Given this list of marker genes PRDX6, MYOM2 (NCBI Gene Id 9172), ENO3, KCNA7, ENSG00000228566, PTGFR, FGF6, PPP1R3A, TCEAL7, FBP2, MYBPC2, C1orf167, UTP11, CACNG1, SLC49A3, AK1, MYOT, LANCL1-AS1, FBXL22, TAS1R1, KLHL31 (NCBI Gene Id 401265), MYLK2, MYL1, MGC27382, LINC00570, SHOX, STAC3, METTL21C, GPX7, LINC03111, LINC02308, TMEM38B, SPEG, PRSS53, LINC01497, LINC01266, SNORD114-29, PDLIM3, FXR1 (NCBI Gene Id 8087), FHL3, TMEM38A, ARHGAP36, MYBPH, RNF217-AS1, ENSG00000259636, CAPN3, TRIM54, LRTM1, TPM2, KLHL41, DHRS7C, NEB, KLHL30, JPH1, TRDN, SGCB, LINC00629, ASB5, FGFRL1, DDN, IL17B, MYF6, BTF3, FAM47E-STBD1, MYH2, LINC00856, OBSCN, FHL1, ACTN3, CKM, BLCAP (NCBI Gene Id 10904), ACTA1, SNORD114-31, TNNC2, PACSIN3, CACNB1, CHRNG, LMCD1 (NCBI Gene Id 29995), MYL10, SNORD114-15, LINC00499, TEAD4, OTUD1, MYL6B, ASTILCS, VWA5A, DDIT4L, CMYA5, TTN-AS1, MYH3, USP6, AMPD1, CA3-AS1, TAL2, ASB18, MAP4K1-AS1 (MAP4K1 antisense RNA 1), BEST3, RYR1, RPS20, LINC01854, SNORD114-26, KLHL21, KIAA1671-AS1, CA3, TMEM52, CAND2, PYGM, PRKACA, HSPB2, CASQ1, PIEZO1P2, GJD4, MRLN, IP6K3, C4orf54, MYOZ1, MYL11, DNAH8, APOBEC2, MAP3K7CL, NES, ATP2A1, FZD9 (NCBI Gene Id 8326), TRIM72, KLHL40, AGL, PPDPFL, ACTN2, CALML6, MIR133A1HG, DGCR6, PPP1R27, FAM180B, DUSP13B, LINC01479 (NCBI Gene Id 101927922), C1orf105, MYPN, PDE4DIPP1, LINC01209, MYL5, ITGB6, DMPK, BIN1, SGCG, LINC01886, ZNF106, FAM230G, TRIM7, MYOM3, SRL, XIRP2, TNNT3, CFL2, DES, ATP1B4, TMEM182, LINCMD1, RPL7P3, MYBPC1, PRR32, TXLNB, KCNE5, MYL6B-AS1, MYH8, MYH1, CAVIN4, PRKAG3 (protein kinase AMP-activated non-catalytic subunit gamma 3), CACNA1S, SNHG16, MIR1-1HG, SRPK3, TNNI2, EIF4E2 (NCBI Gene Id 9470), SMTNL1, MAP6D1, ZNF556, ECPAS (Ecm29 proteasome adaptor and scaffold), SCN4A, RTN2, CRABP2 (NCBI Gene Id 1382), MEG9, SYNC, RPS3AP20, SLN, SNORD114-30, MSRB3-AS1, TBX15, SYPL2, ASB12, CAV3 (NCBI Gene Id 859), TTN, PADI2, STPG2-AS1, here is a description of the gene set: Human Gene Set: DESCARTES_MAIN_FETAL_SKELETAL_MUSCLE_CELLS Marker genes curated from the annotated cluster as represented in the Descartes Human Gene Expression During Development database. studied in species Homo sapiens The gene expression program underlying the specification of human cell types is of fundamental interest. The study authors generated human cell atlases of gene expression and chromatin accessibility in fetal tissues. For gene expression, the study authors applied three-level combinatorial indexing to >110 samples representing 15 organs, ultimately profiling ~4 million single cells. The study authors leveraged the literature and other atlases to identify and annotate hundreds of cell types and subtypes, both within and across tissues. Our analyses focused on organ-specific specializations of broadly distributed cell types (such as blood, endothelial, and epithelial), sites of fetal erythropoiesis (which notably included the adrenal gland), and integration with mouse developmental atlases (such as conserved specification of blood cells). These data represent a rich resource for the exploration of in vivo human gene expression in diverse tissues and cell types. from publication Cao J, O'Day DR, Pliner HA, Kingsley PD, Deng M, Daza RM, Zager MA, Aldinger KA, Blecher-Gonen R, Zhang F, Spielmann M, Palis J, Doherty D, Steemers FJ, Glass IA, Trapnell C, Shendure J (PMID 33184181)